The following is a description of a gene set: from publication Woo HG, Park ES, Cheon JH, Kim JH, Lee JS, Park BJ, Kim W, Park SC, Chung YJ, Kim BG, Yoon JH, Lee HS, Kim CY, Yi NJ, Suh KS, Lee KU, Chu IS, Roskams T, Thorgeirsson SS, Kim YJ (PMID 18381945) PURPOSE: The poor prognosis of hepatocellular carcinoma (HCC) is, in part, due to the high rate of recurrence even after curative resection of tumors. Therefore, it is axiomatic that the development of an effective prognostic prediction model for HCC recurrence after surgery would, at minimum, help to identify in advance those who would most benefit from the treatment, and at best, provide new therapeutic strategies for patients with a high risk of early recurrence. EXPERIMENTAL DESIGN: For the prediction of the recurrence time in patients with HCC, gene expression profiles were generated in 65 HCC patients with hepatitis B infections. RESULT: Recurrence-associated gene expression signatures successfully discriminated between patients at high-risk and low-risk of early recurrence (P=1.9 x 10(-6), log-rank test). To test the consistency and robustness of the recurrence signature, we validated its prognostic power in an independent HCC microarray data set. CD24 was identified as a putative biomarker for the prediction of early recurrence. Genetic network analysis suggested that SP1 and peroxisome proliferator-activated receptor-alpha might have regulatory roles for the early recurrence of HCC. CONCLUSION: We have identified a gene expression signature that effectively predicted early recurrence of HCC independent of microarray platforms and cohorts, and provided novel biological insights into the mechanisms of tumor recurrence. Human Gene Set: WOO_LIVER_CANCER_RECURRENCE_UP species: Homo sapiens Genes positively correlated with recurrence free survival in patients with hepatitis B-related (HBV) hepatocellular carcinoma (HCC)., and this is the list of marker genes: GPC4, TEAD4, LOX (NCBI Gene Id 4015), FGFR2, CXCL6, TGFB1, IGFBP3, SGCB, EVL, TPM2, TMSB10, HKDC1, SEMA3C, HK2, PTMA (prothymosin alpha), CCND2, PPT1, UBR5, PLAGL1, SLIT2, PKM, SOCS1, DPYSL2, LPCAT1, VEGFB, COL1A2 (NCBI Gene Id 1278), SEMA6A, PLAU, DDIT3, RHOF, LAMP3, BCL2, MAPK12, ZEB2 (NCBI Gene Id 9839), COL6A3, PFKM, FLNA, ENPP2, MICAL1, TLK2, CSGALNACT1, CRIP1, TACSTD2, CXCL1, POSTN (NCBI Gene Id 10631), MEF2C, CCL2, COL11A1, TPBG, QSOX1, COL1A1, PFN2, S100A6, MARCKS, PFKP, DUSP4, CXCL8, ARHGEF2, BHLHE41, CCNI (NCBI Gene Id 10983), EFHC1, FGFR1, ARHGAP4, TPM4, ANOS1, TNFRSF25, ALDOA, TSPAN3, MAB21L2, RGS1, TGFB2, EPHA3 (EPH receptor A3), FZD1, DPYSL3, COL9A2, DDR1, PMP22, MGP, GEM, PLCE1, SOX9, RGS2, LAMA4, DBN1, PDGFA, JAG1, NOTCH2, CD24P2, LAMA5, RGS10, GAS7, E2F3, ENO2, FGD6, CCN2, ZNF354A, JAG2, DAB2, TREM2, CRYAB, HMGA1, CCND3, PLAUR, MYO6, EXT1